Given this list of marker genes CHRM1, AQP5, PPP3CA, CHRM3, NEGR1, NEUROG1, TIFAB, FGF10, DCANP1, OPRK1, SLC4A9, STATH, AQP1, NKX2-3, KCNN4, here is a description of the gene set: The regulated release of saliva from the salivary glands. In man, the saliva is a turbid and slightly viscous fluid, generally of an alkaline reaction, and is secreted by the parotid, submaxillary, and sublingual glands. In the mouth the saliva is mixed with the secretion from the buccal glands. In man and many animals, saliva is an important digestive fluid on account of the presence of the peculiar enzyme, ptyalin. Human Gene Set: GOBP_SALIVA_SECRETION studied in species Homo sapiens